The following is a description of a gene set: studied in species Mus musculus Metabolism of steroid hormones Mouse Gene Set: REACTOME_METABOLISM_OF_STEROID_HORMONES, and this is the list of marker genes: Stard4, Hsd17b3, Cyp21a1 (cytochrome P450, family 21, subfamily a, polypeptide 1), Tspo, Hsd3b3, Hsd17b1, Cga, Akr1b1, Akr1b10, Srd5a3, Hsd3b9, Akr1b7, Fdx1, Fdxr, Akr1b8, Pomc, Hsd17b14, Hsd3b8 (hydroxy-delta-5-steroid dehydrogenase, 3 beta- and steroid delta-isomerase 8), Fdx2, Tspoap1, Cyp11a1 (NCBI Gene Id 56432), Hsd17b2, Hsd3b2, Lhb, Srd5a2, Stard3, Cyp17a1, Serpina6, Hsd3b5, Hsd3b4, Hsd11b2, Hsd17b12, Hsd11b1, Star, Hsd3b1, Cyp19a1, Hsd17b11 (hydroxysteroid (17-beta) dehydrogenase 11), Cyp11b2, Stard3nl, Stard6, Srd5a1, Sts, Hsd3b6, Cyp11b1